The following is a description of a gene set: Human Gene Set: GOMF_NEUROPEPTIDE_BINDING Interacting selectively and non-covalently and stoichiometrically with neuropeptides, peptides with direct synaptic effects (peptide neurotransmitters) or indirect modulatory effects on the nervous system (peptide neuromodulators). studied in species Homo sapiens, and this is the list of marker genes: SSTR1, PRLHR, MC3R, SSTR3, GPR37, MRGPRX2, SSTR4, GALR2, GRPR, NPY4R, SSTR2, MCHR1, SORL1, NMUR1, ADCYAP1R1, OPRK1, NPY4R2, GPR149, NPY1R (NCBI Gene Id 4886), MC4R, OPRL1, SSTR5, OPRD1, NPBWR1, CMKLR2, NPY6R, NMUR2, NPY5R, GALR1, GPR171, PTGDR2, OPRM1, NPBWR2